Given this list of marker genes MT3 (metallothionein 3), RNF34, ABCC9, NOX1, FKRP, ME3, LIPT2, FMO2, here is a description of the gene set: studied in species Homo sapiens Human Gene Set: GOBP_OXYGEN_METABOLIC_PROCESS The chemical reactions and pathways involving diatomic oxygen (O2).